Given this list of marker genes SLCO1A2, ABCG2, SLC22A8, SLC22A1, ALB, here is a description of the gene set: Reactome Pathway: Ciprofloxacin ADME species: Homo sapiens part of: Drug ADME Ciprofloxacin (Cipro) is a widely used broad spectrum bacterial antibiotic. Due to its association with disabling and potentially persistent adverse reactions and current high levels of resistance its use is now recommended in patients who have no alternative treatment option for respiratory and urinary tract infections, skin and soft tissue infections, bone and joint infections, infectious diarrhea, typhoid fever and gonorrhea with susceptible strains. Adverse reactions include tendinitis, tendon rupture, peripheral neuropathy, and CNS effects. The usual dosages are 250 mg and 500 mg.<br/><br/>Cipro is highly soluble in aqeuous media below pH 5 and above pH 10. About 60 to 80 percent are taken up by the body. The main absorption site of ciprofloxacin is the upper GI tract, up to the jejunum. In the context of the Biopharmaceutics Classification System (BCS) Cipro is "not highly soluble", and "not highly permeable". It is classified as BCS class 2, 3, and 4, and uptake and efflux transporters have a big effect on its absorption and excretion. BCS class 4 drugs are primarily excreted unchanged via the biliary or renal routes. <br/><br/>Very high concentrations of Cipro with respect to plasma concentrations are seen in kidney and gall bladder; high concentrations are also found in liver, prostatic tissue, and lung. The main excretion routes for unchanged Cipro are renal (about 65% of plasma amount) and intestinal (about 10%). The intestinal figure includes excretion through epithelial GI cells, and through hepatic cells and the bile duct. The rest of plasma Cipro (10 to 20%) is metabolised, with the major species recovered from urine being oxociprofloxacin and, in faeces, sulfociprofloxacin. Both account for about five per cent each of total excretion.